Given this list of marker genes CCSER2, ZBTB48, PRAME, IL1B, HLA-F, SNX11 (sorting nexin 11), FUT7, DCAF6, DUSP1, NFKBIA, MGLL, RUFY3, CD70, CEP43, LMBR1L, P2RY10 (P2Y receptor family member 10), IL21R, KIFBP, TNFRSF1B, RFX1, SINHCAF, SQSTM1, TNFAIP3, CCL22, KXD1, FOXO1, SLAMF7, ADAR, MYL5, TAPBP, TNIP1, GBP1, ALDH2, GADD45B, SBNO2, UVRAG, XPNPEP1, IL4R, STK17B, MCRS1, SLC25A32, CHKB, TNFRSF14, UXS1, PTGES2, VAMP1, KLF7 (KLF transcription factor 7), KIF2A, CDT1, DNAJA1, RPS6KC1, CYP27B1, DENND4A, MMP25 (matrix metallopeptidase 25), PKN1, COL9A2, TWF2, GADD45A (growth arrest and DNA damage inducible alpha), TDRD7, CD40, TBC1D13, BMAL2, BTG3, POLR2B, RALY, TMCC2, RAB11A, RNF115, KMT2A, RASSF2, RAB8B, TPST1, PTK2B, SRGN, ZBTB10, ACY1, STAG3L1, TMEM39A, FBXL8 (NCBI Gene Id 55336), LAMB3, MREG, INSL3, POLI, ANXA6, SS18, LRRFIP2 (LRR binding FLII interacting protein 2), RAB5B (NCBI Gene Id 5869), GGH, CSTA, ALOX15B, IRGQ, ZDHHC14, SMG9, SPECC1L, XPO6, EHBP1L1, F11R, LPCAT1, TIA1, CD84, UBXN4, FSTL1, C1orf115, TAP1, ARHGEF2, SCAMP3, FAM117A, ARHGAP22, MAP4K4, MED12, PPP1R16B, PLEK, SMC4, CYRIA, NFKB1, POLR2J, SELENOW, AOC1, RNF208, SLC6A12, REL, SPRED2 (sprouty related EVH1 domain containing 2), MVP, SLC2A6, EOLA2, TRADD, SDC4, LORICRIN, PSME2, MYO15B, MINDY2, PTPN1, IL32, ENSA, CYLD, TOMM34, SYNPO, HSPA8, MAP4, TBC1D9, TRIP12, LSP1, NOSIP, RASSF4, SPATA2, PERP, RBM10, EBI3, KDM6A, TXN, INTS5, CDC42EP4, AKT3, TANK, RELB, DAAM1, PSME1, UBR4, MYB, DHX9, MGRN1, RAB9A, MCC (MCC regulator of WNT signaling pathway), NDE1, MYO9B, MPC1, PTGIR, FLT3 (NCBI Gene Id 2322), GTDC1, NRP2, PITPNB, AFDN, INPP5K, GALNT11, MRTFA, HSF1, TNFAIP2, GRSF1, USP11, ZSWIM8, JAK1, HARS1, ERICH1, SEC61B, DLD, OTUD4, PDZK1, G0S2, AHCYL2, GAB2, EIF1, BBIP1, ECPAS, FXYD6, CSNK1G3, SLCO5A1, DENND5A, CHST7, FAS, here is a description of the gene set: Genes down-regulated during primary acute viral infection: NK cells versus B lymphocytes. studied in species Homo sapiens Murine Cytomegalovirus (MCMV) infection leads to early activation of various immune cells, including B and T lymphocytes, before the actual initiation of antigen-specific adaptive immunity. This activation is partly driven by innate cytokines, including type I interferon (IFN), which are induced early after infection. The objective of this study was to address the role of type I IFN in shaping early/innate B and T cell responses to a primary acute viral infection. In order to decipher the specific impact of IFN-I on cell subsets, we performed a genome-wide expression analysis on WT splenic B and CD8 T lymphocytes isolated from C57BL/6 mixed bone marrow chimera mice. This study complements series GSE39555, which focused on early responses of NK cells and of the two subsets of conventional dendritic cells. Human Gene Set: GSE45365_NK_CELL_VS_BCELL_MCMV_INFECTION_DN